Given this list of marker genes Irgm1, Tmsb10, Pfn1, Cdkn1a, Stat1, Cxcl9, Cxcl10, Cfl1, H2-Aa, Lima1, here is a description of the gene set: species: Mus musculus Mouse Gene Set: CUI_MIGDC_IL2_RESPONSE_UP from publication Cui A, Huang T, Li S, Ma A, Pérez JL, Sander C, Keskin DB, Wu CJ, Fraenkel E, Hacohen N (PMID 38057668) Cytokines mediate cell-cell communication in the immune system and represent important therapeutic targets. A myriad of studies have highlighted their central role in immune function, yet we lack a global view of the cellular responses of each immune cell type to each cytokine. To address this gap, the authors created the Immune Dictionary, a compendium of single-cell transcriptomic profiles of more than 17 immune cell types in response to each of 86 cytokines (>1,400 cytokine-cell type combinations) in mouse lymph nodes in vivo. A cytokine-centric view of the dictionary revealed that most cytokines induce highly cell-type-specific responses. For example, the inflammatory cytokine interleukin-1β induces distinct gene programmes in almost every cell type. A cell-type-centric view of the dictionary identified more than 66 cytokine-driven cellular polarization states across immune cell types, including previously uncharacterized states such as an interleukin-18-induced polyfunctional natural killer cell state. Genes positively differentially expressed in cell type: MigDC (migratory dendritic cell) upon treatment with cytokine: IL-2 in mouse lymph nodes in vivo.